The following is a description of a gene set: Human Gene Set: GOBP_NEGATIVE_REGULATION_OF_PLASMA_MEMBRANE_BOUNDED_CELL_PROJECTION_ASSEMBLY species: Homo sapiens Any process that stops, prevents or reduces the frequency, rate or extent of plasma membrane bounded cell projection assembly., and this is the list of marker genes: TACSTD2, LIMK2, MARCHF7, AKT1, PFN2, ARHGAP24, YAP1, PLXNB3, PRKCD, SRGAP2C, TRIM32, LPAR1, CFL1, MIR196A1, LIMA1, KIF24, ABI3, GDI2, ARHGAP44, MAP4, CEP97, KANK1, ODF2L, MIR214, STAP1, RAB3IP, RAP1GAP, MPHOSPH9, CDK10, EVI5L, HRG, LUZP1, NRXN1, MAK, CCP110, TBC1D30, TBC1D7, WDR44, SLIT2, CCL21, TESK1, TCHP, EVL